The following is a description of a gene set: studied in species Homo sapiens Genes down-regulated in comparison of type 2 myeloid (T2M) cells treated with IL25 versus macrophages treated with IL25. from publication Petersen BC, Budelsky AL, Baptist AP, Schaller MA, Lukacs NW (PMID 22543263) Human Gene Set: GSE36392_TYPE_2_MYELOID_VS_MAC_IL25_TREATED_LUNG_DN Many symptoms associated with allergic asthma result from the sequelae of type 2 inflammation. Interleukin (IL)-25 promotes type 2 inflammatory responses, and T2M cells represent an IL-4 and IL-13 producing granulocytic IL-25 responsive population. We used microarrays to characterize the gene expression profile of T2M cells, and compared T2M cells to other inflammatory subsets (eosinophils, neutrophils, and macrophages) in the lungs of mice with IL-25-induced pulmonary inflammation., and this is the list of marker genes: SEPTIN3, NXT1, ZKSCAN4, HDAC9, YARS1, SNHG12, DRG2, CARMIL1, NDUFAF1, CELF4, RASGRF2, RGL2, FANCF (FA complementation group F), PIANP, SEC11A, NOP10, MAPKBP1, MTARC2, COPS7A, RUVBL2, ASCC1, FBXL4, PPP5C, PYGB, CDKN2AIPNL, GTF3A, SMIM7, VIRMA, SRRM1, BEX3, PGAP6, PARP9, ABRAXAS1, RPS6KA4, SLC12A9, MAGED1, TRAPPC3, HINT2, WDR12, CSAD, MANSC1, SPIB, PSIP1, ZNF764, GATC, SUSD3, CNOT8 (CCR4-NOT transcription complex subunit 8), MRPL18, SMIM5, CD79B, TNFRSF11A, TEPSIN, ZNF524, ELOF1, PLCL1, RAB43, POLD3, JMJD8, MED20, EIF4G3, SH2B2, SLCO5A1, ALDH1B1, NOSIP, ERGIC3, DUSP19, BRSK1, ALKBH2, FKRP, IDUA, VPS28, CACTIN, MGAT1, PXYLP1, MLLT1, SEC31A, PEX16, ICMT, LMF1, MRS2, TRAPPC5, WDR74, GBF1, RTL8C, LMO1, LSM2, HSF1, RIC8B, DPP3 (dipeptidyl peptidase 3), TTLL12, GGT5, KAT7, METTL8, MCAT, ANTKMT (NCBI Gene Id 82377), NELFA, FKBP4, REV1, SUDS3, CHCHD5, IDH2, TFEB, TSNAX, AFDN, FUOM, CZIB, PRMT1, TMEM208, GPR19, HASPIN, LRP1, IQCE, CSTF1, ZNF862, ARHGAP42, RPL17, UBE2G2 (ubiquitin conjugating enzyme E2 G2), CEBPA, EXOSC5, MRPS18B, NIPSNAP1, POLR1A, GP2, ZFAND1, B4GALT4, ALKBH8, DCXR, SLC5A2, AXIN1, DET1, SUPT16H, SRPK1, TMEM69, HSCB, PDCD11, MIPEP, PLXND1, ATPSCKMT (NCBI Gene Id 134145), TMOD4, GPBP1L1, NOP2, ZKSCAN5, TNIP2, ADPRS, STRIP2, USP34, STBD1, USP15, DSCAM, SIAH2, ADD3, AKNA, TYSND1, ME2, FAM53B, FCMR, ELMO2, STAMBP, KLF2, AHRR, TTC27 (tetratricopeptide repeat domain 27), ADCK2, FBL, MBLAC2, RGS12, GMPR2, SIRT4, MOGS, HAAO, ALKBH7, C1orf50, PRCP, GET4, NXPE4, PDRG1, EIF1B, STX16, ATG2A, KLHL42, NCOR2, PPIL2, SAP18, BBS9, PLP2, HMGCL, RNF10, PCK2, NEK8, CTNND2, MOB3A, MAP2K5, FOXRED2, PRKCE, ABHD17A, MED24, TRIM14, SIRT2, ZNF467, APEH, CAMLG